The following is a description of a gene set: The increase in size or mass of an organ. Organs are commonly observed as visibly distinct structures, but may also exist as loosely associated clusters of cells that function together as to perform a specific function. studied in species Mus musculus Mouse Gene Set: GOBP_ORGAN_GROWTH, and this is the list of marker genes: Trp73, Ccnd2, Matn1, Myh10, Acacb, Plag1, Rgs4, Adra1b, Poc1a, Nppc, Sorbs2, Serp1, Akap6, Igf1, Gsk3b, Map2k4, Il7, Ccnb1, Cst5, Rbp4, Myocd, Yy1, Tgfbr3, Pim1, Bcl2, Fgf8, Stk3, Mael, Akt1, Prkg1, Pdgfra, Lepr, Ccm2l, Ly6e, Pin1rt1, Ttn, Bcl2l11, Shh, Rln1, Thbs3, Prlr, Tbx20, Flvcr1, Comp, Cacna2d2, Vgll4, Lep, Slc6a4, Mapk1, Smad2, Tgfb2, Ecm1, Fgf10, Enpp1, Erbb4, Arid2, Rarg, Npr2, Fgf7, Carm1, Dipk2a, Abl1, Stk4, Spry2, Heg1, Ccn4, Bmpr1a, Ptpn11, Ext1, Fdps, Adra1a, Ncam1, Sox9, Adprhl1, Mef2c, Smad1, Hamp, Ctdp1, Rbpj, Bnc2, Pdlim5, Mtor, Cga, 2810429I04Rik, Cxadr, Dyrk1a, Mir133a-1, Ift80, Rarb, Ptk2, Wt1, Mapk14, Psap, Adrb1, Ddr2, Tgfbr2, Agtr2, Psapl1, Col14a1, Fgf20, Rgs2, Ankrd26, Ahr, Cldn18, Col9a1, Pin1, Fgfr2, Gata4 (NCBI Gene Id 14463), Nrg1, Hamp2, Lmx1b, Fes, Rspo2, Nr3c1, Tcf7l2, Men1 (multiple endocrine neoplasia 1), Cdk1, Camk2d, Mir1a-2, Fosl2, Ang2, Notch1, Cited2, Sirt6 (sirtuin 6), Mir133a-2, G6pdx, Fgf1, Zfpm2, Kdr, Prkar1a, Foxc2, Yap1, S1pr1, Dusp6 (dual specificity phosphatase 6), Ppara, Map7, Agt (angiotensinogen), Pdgfrb, Myh6 (NCBI Gene Id 268746), Acvr2b, Pak1, Rxra, Bmp10, Cyp19a1, Fxn, Kcnk2, Rag2, Gata6, Nog, Lats1, G6pd2, Zmpste24, Apc, Gsk3a, Smpd3, Ar, Ctnnb1, Nkx2-5, Ube3a, Ier3ip1, Thbs1, Zfp418, Tgfbr1, Tomm70a, Cer1, Rxrb, Parp2, Slc25a4, Tbx2, Pi16, Por, Nlgn4l, Ddx39b, Sav1, Gli1, Fgf9, Igf2, Arx, Esr1, Pten, Sirt1, Edn1, Mmp13, Akap13, Msx2, Foxp1, Dll1, Tenm4, Fbln5, Foxc1, Gje1, Ybx3, Fgf2, Prox1, Tmem38b, Mir208a, Mapk11, Cav3, Rara (NCBI Gene Id 19401), Rbm10, Tbx1, Evc, Mesp1, Jarid2, Ehmt2, Ski, Dspp, Trip10, Hlx, Ostn, Hey2, Sash3, Tbx5, Stc1, Hdac2, Atf2, Col27a1, Meis1, Fgfr1, Smo, Wnt2, Cacna1c, Gja1, Ep300, Wwc1, Wwc2, Lats2